The following is a description of a gene set: Genes down-regulated in CD4 SMARTA memory T cells: Th1 versus Ly6c int CXCR5+. CD4 T follicular helper (Tfh) cells provide the required signals to B cells for germinal center reactions that are necessary for longlived antibody responses. However, it remains unclear whether there are CD4+ memory T cells committed to the Tfh lineage after antigen clearance. Using adoptive transfer of antigen-specific memory CD4+ subpopulations (based on CXCR5 and Ly6c expression)in the LCMV infection model, we found that there are distinct memory CD4+ T cell populations with commitment to the Tfh and Th1 lineages. Our conclusions are based on gene expression profiles, epigenetic studies and phenotypic and functional analysis. The gene expression profiles of virus-specific CD4 T cell subets at effector and memory stages is presented here. from publication Hale JS, Youngblood B, Latner DR, Mohammed AU, Ye L, Akondy RS, Wu T, Iyer SS, Ahmed R (PMID 23583644) species: Homo sapiens Human Gene Set: GSE43863_TH1_VS_LY6C_INT_CXCR5POS_MEMORY_CD4_TCELL_DN, and this is the list of marker genes: CD5L, NPL, DDB2 (damage specific DNA binding protein 2), ABCG1 (ATP binding cassette subfamily G member 1), GAB1, CD1D, NOX4, LHX9 (NCBI Gene Id 56956), RAB25, GATD1, RASSF3, FRAT1, CPNE8, GJB2, LRP1, C1QC, L1CAM (L1 cell adhesion molecule), LTBP3, CLEC1B, FNIP2, NMNAT2, MRC1, HSF2BP (NCBI Gene Id 11077), RPS6KA5, ZNF667, ADAMDEC1, ACRV1, NR1I2, CIP2A, WNT11, SPP1, HRH2, STK10, WNT1, KHDRBS3, NIBAN2, BACH2, SLC4A9, SMO, SPRR3, WFIKKN1, AMDHD1, SIM2, RAPGEF4, KLF2, IRF2BP2, CFAP97D1, MBNL2, SELENOP, MORN4, RNF144A, FABP12, SLC22A25, TBC1D2B, ADGRA1, RTBDN, NODAL, PRSS35, ZFPM1, TNKS1BP1, BNC1, ACAP1, RGS10, GPR35, SLC17A9, MORN1, DNALI1, LIMA1, PRODH2, SP6, RGS2, ZC2HC1B, VSIG8, PLA2G15, ABCA2, ASGR2, CSF1R, TCIRG1, SYT16, NFIC, SPATA4, C1QA, SLC11A1, PDGFA, LASP1, SLC25A23, CD27, CATSPERZ, ARRDC1, NDN, KRTAP17-1, TBL1XR1, CCDC24, OXLD1, GPR37, ZNF784, DRC12, POU3F4, PIR, GJB1, ZNF365, CAMK2G, ALDOB (NCBI Gene Id 229), CCDC106, CD226, ADGRL1, CTSB, STK40 (NCBI Gene Id 83931), IL17RB, ARMH4, GDI1, TNIK, CARTPT, B3GNT7, AGAP1, GPR137B, TMLHE, HOXA3, CD68, PPP1R3G, PLPP3, CD300LB (CD300 molecule like family member b), AMHR2, SLC22A16, SERPINB6, MMP19, ADAM8, SAA2, EFEMP1, LGI2, ABCB4, FCGRT, SUSD6, CPA1, SLC8B1, ZNF385A, OLAH, PDE9A, CA1, CFAP184, KCNQ1, ABCA1, C1QB, KMT2E, SERAC1 (serine active site containing 1), TM4SF20, TGM1, PLCG1, PARD6G, CKB, SNAP25, FSTL5, HAL, EPHB2, EPCAM, ANKS4B, FBXL19, RNF122, GPT2, SPDYA, CBS, COQ8A, PBX2, HMGCLL1, EPB41L3, FBXO16, MERTK, LAT2, GJB4, KLRC2, ANPEP, VCAM1, AQP7, SENP7, RETREG1, PTK2B, CD300A, GSG1, PLD2, TFAP2B, WDR13, TPM2, PFKM, CREG2, SGSH, FCER1A, PCP4 (Purkinje cell protein 4), SCML4, ZFP36L1, XIST, B3GNT2, BICRAL, OCSTAMP, TMEM98, ADGRE5, SLC40A1, TF, SMPX, DAPL1, CSNK1D